The following is a description of a gene set: studied in species Homo sapiens Human Gene Set: GOBP_ISOCITRATE_METABOLIC_PROCESS The chemical reactions and pathways involving isocitrate, the anion of isocitric acid, 1-hydroxy-1,2,3-propanetricarboxylic acid. Isocitrate is an important intermediate in the TCA cycle and the glycoxylate cycle., and this is the list of marker genes: IDH1, IDH3G, IDH3A, IDH3B, IDH2